The following is a description of a gene set: Human Gene Set: GSE37533_UNTREATED_VS_PIOGLIZATONE_TREATED_CD4_TCELL_FOXP3_TRASDUCED_CD4_TCELL_DN from publication Cipolletta D, Feuerer M, Li A, Kamei N, Lee J, Shoelson SE, Benoist C, Mathis D (PMID 22722857) Genes down-regulated in CD4 T cells over-expressing FOXP3: untreated versus pioglitazone. We identified Pparg as a major orchestrator of the phenotype of adipose-tissue resident regulatory T cells (VAT Tregs). To explore the contribution of Pparg1 and 2 in the generation of the VAT Tregs-specific gene signatures, CD4+FoxP3- T cells were transduced with Foxp3+/- Pparg1 (or Pparg2), treated with Pioglitazone or vehicle, and double sorted for microarray analysis. studied in species Homo sapiens, and this is the list of marker genes: MIR130B, GTF2IRD1, CHD9 (NCBI Gene Id 80205), KTN1, HSPB6, NLGN2, COG4, SAP30, BAAT, LMTK2, PIP4K2A, PTGS2, CYP8B1, TAP1, CD79B, TANC1, USP40, MKRN2, HYI, HSD17B4, KLF5, BRI3, DAB2, SLC4A4, KIF3A, MOSPD1 (NCBI Gene Id 56180), CENPN, TPMT, WSB2, RBM46, PTMS, WDFY2, IKBIP, DHRS9, MUSK, POLB, PLCB2, GNA13, RNF180, CASP3, ZFP57, KRTAP4-2, NFXL1, CALML3, TRAPPC9, CCDC107, LRRC4C, CCDC69, FAM53C, PDLIM4, MATK, SCX (scleraxis bHLH transcription factor), ABCA4, PIGN, PSMA7, BATF3, CCDC34, CREB3L4, MELK, CRISP3, OTOP2 (otopetrin 2), MAMSTR (NCBI Gene Id 284358), CEBPZ, NAV3, ZFAND5, ECE2, ST6GAL1, EAF2 (NCBI Gene Id 55840), NDST2 (N-deacetylase and N-sulfotransferase 2), MYO18A, IL33, MEOX1, NCKAP5, SFXN1, NECTIN1, AMZ1, GTPBP1 (NCBI Gene Id 9567), TMPRSS11E, CRACR2B, RNASE6, SDF2L1, STK4, MORC4, GJA1, DPF2, DYRK1B, TMEM59L, ADCY4, RIN2, PLAU, SLC25A10, UBE2L3, DCTN2, TTBK2, IL10RA, TRPV2, MALT1, MARVELD1, TTBK1, STX11, GPR149, RPL11, FBXL8, L3MBTL4, AGAP1, CD19, NMRK1, PNLDC1, FHAD1, FAM110C, STAMBP, ROPN1L, TPTE, STARD3, NRG4, RPS19, CENPM, SCN2B, TTC7A, MCEE, KRTCAP3, TMEM219, BEX3, MINDY4, MRGPRG, ATRNL1, SERINC5, SOD1, METTL17, BMI1, NPL, ZNFX1, NPC2, TDRD9, PRDX1, MYH7B, EPS15, HFE, INO80D (NCBI Gene Id 54891), GRHPR, GRB2, VPS26C, DPH5, MRPL42, SLC1A1, HMOX1, KIT, INTS8, TRERF1, CLIP1, ARPC3, PIEZO1, EIF3K (eukaryotic translation initiation factor 3 subunit K), CWH43, CAMLG, GATB, PAMR1, ECI2, FANCA, APIP, GCNT7, TBX5